The following is a description of a gene set: studied in species Homo sapiens Human Gene Set: GSE18893_TCONV_VS_TREG_24H_TNF_STIM_UP Genes up-regulated in lymphocytes treated with TNF for 24h: T conv versus T reg cells. from publication Nagar M, Jacob-Hirsch J, Vernitsky H, Berkun Y, Ben-Horin S, Amariglio N, Bank I, Kloog Y, Rechavi G, Goldstein I (PMID 20181891) Here we show that tumor necrosis factor (TNF) induced in human T-regulatory cells (Treg), as compared to conventional T cells (Tcon), a transcription program highly enriched for typical NF-κB target genes, such as: the cytokines LTA and TNF; the TNF-receptor super family members FAS, 4-1BB and OX-40; various anti-apoptotic genes; and other important immune-response genes. As an initial approach to examine the cellular program induced by TNF in Tregs versus Tcon cells, we employed microarray gene expression analysis at 2 and 24 hrs following TNF treatment., and this is the list of marker genes: CDC6, TCF19, ATP5MC3, PPA2, ESCO2, SPC24, CDCA5, BCL2L12, BOLA3, DUT, C21orf58, HAUS7, CCDC15, SLC27A2, TRIM59, LSM4, MRPS21, NUDT1 (NCBI Gene Id 4521), RAD51AP1, VPS25, MCM4, DLAT (NCBI Gene Id 1737), MSH6, H2AZ1, TPRKB (NCBI Gene Id 51002), DDIAS, MRPL39, NUP35, SLC37A4, CDT1, NSMCE2, CHID1, NDUFA2, ACTL6A, GINS3, DDT, RSL24D1, NDUFA8, CENPU, BRCA1, HMGB3, MYBL2, DYNC2I2, RNF26, AK2, BUB3, CAD, PSMC3IP, GMNN, MRPL12, TRAP1, SKA1, CKS1B, RFC4, ZWILCH, MPV17, UBL4A, E2F1, HSPA14, VRK1, PKP4, SUV39H1, HMBS, NUP155, ATP5PO, UFD1, TMEM258, CMTM1, DARS2, CDCA3, MRPL35, ETFB (electron transfer flavoprotein subunit beta, NCBI Gene Id 2109), DEPDC1B, MRPL57, CYC1, FASN, MLLT11, KNTC1, CUTA, FAM111A, GFER, PTTG1, PCNA, NDUFB3, POLA1, CTNNAL1, SAPCD2, NUDT21, KNL1, EXOSC7, E2F7, ILF2, PSMD13 (NCBI Gene Id 5719), CDC23, NIT2, TPI1, COQ3, FBXO5, CCNF, ETFA, PLGRKT, CDK2, IPO5, ARMC10, CHCHD2 (NCBI Gene Id 92547), SFXN4, MSH2, EIF3I, CENPN, CCNE2, TROAP, KGD4 (alpha-ketoglutarate dehydrogenase subunit 4), TUBA1B, ERI2, MRPL41, FIGNL1, CKS2, RRM1, ERCC6L, PRDX2, COX8A, DMAC2, SGO1, BRIP1, HELLS, GINS1, RNASEH2A, DBF4, MCM2, BORA, NDUFB9, TEX30, CDC25A, MCAM, FAHD2A, EID1, DCUN1D5, MICOS13 (NCBI Gene Id 125988), BTF3, CENPJ, MRPL4, COX6C, TPGS2, SDHB, C1orf131, PRIM2, CIT, CDCA7, PRKDC, RANBP1, ATP5MG, DDX41, ITGB3BP, FAM98B, TICRR, TMPO, H2AX, JPT1, TUBB, SPCS1, MRPS18A, CHTF18, DNAJC19, CHAF1B, CBR1, CLIC1, POLD1, UHRF1, TMEM97, POLA2, ERI1, APOO, BHLHE40, PSMC2, PSRC1, PDZD11, COQ9, MFHAS1, GOT2, MCM7, RCCD1, DHCR24, ERGIC3, C19orf48P, TFRC, GSS, RACGAP1, PUSL1, RTCB, HIKESHI, HPF1, NMRAL1, PPCDC (phosphopantothenoylcysteine decarboxylase), RFC2, KIF15, METAP2, CRIP1, TTLL12, CABLES2, CCDC34